The following is a description of a gene set: species: Homo sapiens from publication Belyaev NN, Biró J, Athanasakis D, Fernandez-Reyes D, Potocnik AJ (PMID 22581009) Human Gene Set: GSE24142_EARLY_THYMIC_PROGENITOR_VS_DN3_THYMOCYTE_ADULT_DN Genes down-regulated in comparison of adult thymic progenitors versus adult DN3 thymocytes. Development of T-cells provides a unique opportunity to study cell-fate determination due to the accessability and the well defined stages of developmental stages. In order to understand the genetic programs underlying fetal and adult T‑cell fate specification we subjected highly purified fetal and adult T-cell progenitor populations to a genome‑wide transcriptional analysis. The aim was to identify molecular elements that govern T-cell fate specification as a whole but ultimately to isolate elements that were specific for a given population in a specific developmental window., and this is the list of marker genes: NFKBIE, CPSF4L, BLVRA, TNFAIP8L1, DHX40, HIBADH (3-hydroxyisobutyrate dehydrogenase), PRKCA, KHDC1L, PRAF2, CD247, MRPS33, RAB8A, PNO1 (NCBI Gene Id 80711), MRPS26, DESI1, AHI1, FKBP5, H19, GPHN, UBL4A, DGKE, EPCAM, POLR2F, MST1R, MYG1, MCUB, SEMA4A, GCOM1, GRAP2, CCT7, NAF1, REX1BD, PPIC, CHD1L, IKZF4, NR3C1, ITM2C, MBD2, SEPTIN6, MRPL49, SYNJ2, DDC, PSMB5, SIT1, XBP1, TUBB2B, SLAMF6, CKAP2, ADA, CHUK, SLC35D1, NEFH, NSG1, C18orf32, TCF12 (NCBI Gene Id 6938), CAMKV, TNFRSF18, NDUFAF3, SLC35B3, ID3, SLAIN1, PSMB10, CHURC1, SYAP1, TMEM131, OSTC, SOCS1, PITHD1, PRKCQ, RPL11, SH2D1A, DDX47, RHOA, ACTN1, DGKA (diacylglycerol kinase alpha), SPATS2, PMM1, BST1, HCCS, MRPL55, ENDOU, HSDL2, EXOSC2, QNG1, NOC2L (NCBI Gene Id 26155), EMC3, RPL36A, TUBB3, RFXAP, PTPRF, PGAM2, CD28, GBP6, BCL11B, SYF2, TM7SF2, CAPZA3 (NCBI Gene Id 93661), NCKAP1, ARPP21, SYTL3, ITGA6, TPP2, MRPL12, GSR, HMGCS2, RAG1, AP3S1, ENTPD5, MS4A6A, RGS14, LCK, RRAS2, LIPG, EIF5A, SUN2, MPC1, PHTF1, EMC7, PFN2, PLXDC2, CHCHD3 (NCBI Gene Id 54927), UTP4, ATP1B1, CDK6, TIMM13, GFRA1, NDUFS1 (NADH:ubiquinone oxidoreductase core subunit S1), PLIN3, ATP8A1, RRP1, TRDMT1, AGFG1, PLD4 (NCBI Gene Id 414770), PHF2, ACAA2, SEC24D, NGLY1, ZW10, AHR, CBL, CRCP, MAPKAPK5, MLLT3, CNTNAP2, CDC42SE2, PTCRA, SLAMF1, INSL5, INO80C, RAG2, PDLIM5, NME3, ADGRD1, SH3KBP1, CDC34, TUBG2, TMEM50B, SLC35B1, HMGA1, FBLN2, RPL24, ITK, RHOH, GZMA, ANXA2, TM9SF1, UBE2D3 (NCBI Gene Id 7323), CD3D (NCBI Gene Id 915), PRKCB, TMEM134, SLC66A3, SF3B5, HSD11B1, POLM, ERP44, MPZL2, TMEM165, GDPD1, CD3G, CLTB, MICOS13, SVIL, GALNT10, GTF2H2, BHLHE40, SAPCD1, PLA2G12A, NCK2, ERCC8, STIP1, C1QTNF1, AXL, LEF1, BMAL1, IL2RA, PLD3, SMO, TCOF1, MVK (NCBI Gene Id 4598), HMCES